The following is a description of a gene set: from publication Ouillette P, Erba H, Kujawski L, Kaminski M, Shedden K, Malek SN (PMID 18281475) Human Gene Set: OUILLETTE_CLL_13Q14_DELETION_DN Genes down-regulated in chronic lymphocytic leukemia (CLL) samples bearing deletions in the 13q14 region. studied in species Homo sapiens Chronic lymphocytic leukemia (CLL) is a biologically heterogeneous illness with a variable clinical course. Loss of chromosomal material on chromosome 13 at cytoband 13q14 is the most frequent genetic abnormality in CLL, but the molecular aberrations underlying del13q14 in CLL remain incompletely characterized. We analyzed 171 CLL cases for loss of heterozygosity and subchromosomal copy loss on chromosome 13 in DNA from fluorescence-activated cell sorting-sorted CD19(+) cells and paired buccal cells using the Affymetrix XbaI 50k SNP array platform. The resulting high-resolution genomic maps, together with array-based measurements of expression levels of RNA in CLL cases with and without del13q14 and quantitative PCR-based expression analysis of selected genes, support the following conclusions: (a) del13q14 is heterogeneous and composed of multiple subtypes, with deletion of Rb or the miR15a/miR16 loci serving as anatomic landmarks, respectively; (b) del13q14 type Ia deletions are relatively uniform in length and extend from breakpoints close to the miR15a/miR16 cluster to a newly identified telomeric breakpoint cluster at the approximately 50.2 to 50.5 Mb physical position; (c) LATS2 RNA levels are approximately 2.6-fold to 2.8-fold lower in cases with del13q14 type I that do not delete Rb, as opposed to del13q14 type II or all other CLL cases; (d) PHLPP RNA is absent in approximately 50% of CLL cases with del13q14; and (e) approximately 15% of CLL cases display marked reductions in miR15a/miR16 expression that are often but not invariably associated with bi-allelic miR15a/miR16 loss. These data should aid future investigations into biological differences imparted on CLL by different del13q14 subtypes., and this is the list of marker genes: KLHL21, DUSP6, SCIN, CCDC107, BBOF1, ALDH1B1 (aldehyde dehydrogenase 1 family member B1), MAPT, BACE1, MARVELD1, ULK2, ZNF727, DLEU1, PARP9, EEF2K, CDK5R1, MYBL2, SLA2, DOK3, PLA2G12A, LTB4R, ADAMTS6, RRAGC, PLG, XXYLT1, LINC02580, CYB561, DDAH1, GRK5, DDR1, MLLT3, GFPT2 (NCBI Gene Id 9945), RNASEH2B, ACOT4, CISH, PHLPP1, LINC02848, LATS2, TRIM7, SERPINE2, ENO2, SIPA1L2, ESYT2, DLEU2, GSDME, PKD2, GTSF1L, CASP6, CDK2AP1, TRIM13, BIK, LPIN1 (lipin 1), AQP3, BSPRY, IKZF2, FZD3